Given this list of marker genes PLIN2, UBR5, BMP2, RBP1, NRXN3, DNAJC9, S1PR1, SWAP70, EVPL, ME3, ZNF264, SPOCK1, PNMA2, LGALS8, ZHX2, TRIM2, NUMB, PRMT2, OIP5, NDN, OPRD1, TLK1, PRH1, RAB3GAP2, RAB1A, BNIP2, TNFRSF1A, EXOSC9, POR, ATM, BMP6, SEC14L1, CHST15, PNN, COL4A6, IGF1, ID4, RARA, CD36, HMGA2, PLN, GUSB (glucuronidase beta), VWA8, DUSP8, PDE8A, CSNK1A1, IRF1, HTRA1, LTBP2, CHAF1B, PDE6H, ZNF629, FLRT2, SSBP2, MTERF1, LCN1, ATP13A3, DDR2, CCL20, ZFP36L1, ERC2, C10orf95-AS1, HRH1, CLCN3, KRIT1, HIF1A, ITGAE, PAFAH1B1, STXBP5L, PTCH1, CIITA, HNMT, PC, TROAP, PLPP3, NPY6R, KLHL20, LITAF, RPP38, THBS1, PIN4, CD163, GRAMD4, ZMYND11, DICER1, RBPJ, DCC, HIVEP2, ARID3A, HADHB, BASP1, ITGB1, KANK3, ATP5MG, CD86, GNA15, SNRNP200, OSBPL8, GBE1, SACM1L, SST, ITSN1, STAT4, ZNF200, NPTN, SOX30, FRMD4B, UBFD1, MFAP3, CCN4, RCBTB2, TERF2IP, CREG1, MXRA7, FOXD2, CSF1R, NELL1, USH1C, TBC1D8, DDX46, MAD2L1, OLFML2B, TCFL5, BCL6, TOR1B, FABP4, UGT2B11, SGSH, ARHGAP25, SSX5, PIKFYVE, RAD51AP1, CEP170, FKTN, H3C10, PHLDA1, TRAPPC8, DCUN1D4, KBTBD2, NNT, CHKB, SDC2, ADAM9, MYOG, FBXL5, JOSD1, CREM, PTPN2, RRAGB, KRT10, SLC5A3, THEMIS2, PPFIBP1, ZMIZ1, STARD13, DIO3, SCYL3, MTHFS, TIMP1, NPC1, IRF2BP1, PICALM, CRX, CSTF1, IL1R1, VPS26A, PPP2CA, MTCL1, CDKL2, IFNGR1, SMOX, GJC2, TRIB1, TBR1, AK1, PCGF3, ADCY3, FAM168A, ANKS1A, MAGEA12, PALLD, TFPI, CTCF, CD9, ID3, CELF2, SDS, CD70, OR2H1, KIAA1549L, LUM, QKI, GEM, GPR65, ATAD2B, BRCA2, TWF1, TSPAN3, RWDD3, XBP1 (X-box binding protein 1), here is a description of the gene set: Mice were immunized with PCC (pigeon cytochrome c). species: Homo sapiens from publication Fazilleau N, Eisenbraun MD, Malherbe L, Ebright JN, Pogue-Caley RR, McHeyzer-Williams LJ, McHeyzer-Williams MG (PMID 17529982) Genes up-regulated in CD4 T cells from lymph nodes: naïve versus day 28 after immunization. Human Gene Set: GSE7548_DAY7_VS_DAY28_PCC_IMMUNIZATION_CD4_TCELL_UP